The following is a description of a gene set: electronically inferred by orthology from the curated human pathway part of: Toll-like Receptor Cascades This event has been computationally inferred from an event that has been demonstrated in another species.<p>The inference is based on the homology mapping from PANTHER. Briefly, reactions for which all involved PhysicalEntities (in input, output and catalyst) have a mapped orthologue/paralogue (for complexes at least 75% of components must have a mapping) are inferred to the other species. studied in species Mus musculus Reactome Pathway: Toll Like Receptor 3 (TLR3) Cascade, and this is the list of marker genes: Ube2n, Tifa, Map2k4, Ppp2r5d, Map3k8, Nfkb2, Rela, Jun, S100b, Mapk9, Hmgb1, Nlrx1, Tab3, Ube2v1, Tab1, Nkiras1, Mapk8, Casp8 (caspase 8), Rps27a, Nfkbia, Map2k6, Vrk3 (vaccinia related kinase 3), Fos, Tab2, Ubb, Nfkb1, Irf7, Lrrc14, Irf3, Map2k3, Ager, Ppp2r1b, Mapk11, Nlrc5, Nfkbib (NCBI Gene Id 18036), Cul1, Mapk7, Mapk3, Dusp7, Dusp6, Irak1, Ikbkb, Rps6ka5, Map2k7, Mapk14